Given this list of marker genes MLH1, PMS1, PMS2P5, RAD51B, PMS2P1, PMS2P3, MSH3, RAD51D, MSH2, SIRT6, PMS2P6, PMS2, RAD23B, RAD51, MSH6, XRCC3, MSH4, XPC, RAD51C, MSH5, ERCC6, MLH3, XRCC2, DMC1, UHRF1 (ubiquitin like with PHD and ring finger domains 1), here is a description of the gene set: A molecule that recognises toxic DNA structures, for example, double-strand breaks or collapsed replication forks, and initiates a signaling response. studied in species Homo sapiens Human Gene Set: GOMF_DNA_DAMAGE_SENSOR_ACTIVITY